The following is a description of a gene set: Mouse Gene Set: GOBP_POSITIVE_REGULATION_OF_DNA_REPAIR species: Mus musculus Any process that activates or increases the frequency, rate or extent of DNA repair., and this is the list of marker genes: Morf4l1, Fmn2, Apbb1, Rnf168, Parp3, Ino80b, Egfr, Dpf2, Atm, Rad51ap1, Ercc8, Ruvbl2 (RuvB-like AAA ATPase 2), Ep400, Brcc3dc, Yeats4, Arid1a, Pnp, Rnf8, Smarcd2, Pcna, Mrgbp, Actr5, Ing3, Smarce1, Mbtd1, Shld2, Uimc1, Helq, Cbx8, Mre11a, Stk19, Bcl7c (NCBI Gene Id 233901), Shld3, Eya2, Cebpg, Epc2, Wrap53, Prkdc, Morf4l2, Hdac10, Uchl5, Abraxas1, Hdgfl2, Actl6b, Rif1, Smarcd3, Smchd1, Sirt1, Vps72, Actr2, Parg, Was, Dpf1, Phf10, Spire2, Bcl7a, Fgf10, Mad2l2, Smarcc2, Eya3, Kdm4d, Ddx11, Spire1, Yy1, Prmt1, Peli1, Nfrkb, Skp2 (S-phase kinase-associated protein 2), Parp1, Pbrm1, Mcrs1, Slf1, Smarca4, Eya4, Meaf6, Dmap1, Kmt5c, Kmt5b, Eya1, Ruvbl1, Babam2, Xrcc1, Fam168a, Brca1, Rnf126, Shld1, Fus, Smarcb1, Crebbp, Tigar, Brd7, Prkcg, Smarca2, Arid2, Babam1, Wdr48, Bcl7b, Rps3 (NCBI Gene Id 52418), Trim28, Khdc3, Dhx9, Ager, Blm, Ino80d, Tfpt, Smarcc1, Dpf3, Sirt6, Slf2, Top2b, Zcwpw1, Foxm1, Actl6a, Ube2v2, Fancb, Cyren, Mrnip, Pnkp, Ercc6, Ooep, Brd8, Smarcd1, Hmgb1, Epc1, Ube2n, Ino80c, Trrap, Mgmt, Ccdc117, Nbn, Pias4 (protein inhibitor of activated STAT 4), Spidr, Fh1, Actr8, Setmar, Ino80, Brcc3 (BRCA1/BRCA2-containing complex, subunit 3), Kat5, Actb, Tmem161a, Npas2, Timeless